Given this list of marker genes FASLG, FAS (Fas cell surface death receptor), MAP3K5, DAXX, MAPK8, MAPK9, MAPK10, here is a description of the gene set: Pathway Definition from KEGG: FASLG -> FAS -> (DAXX+ASK1) -> JNK studied in species Homo sapiens Human Gene Set: KEGG_MEDICUS_REFERENCE_FAS_JNK_SIGNALING_PATHWAY FAS-JNK signaling pathway. Pathway ID: N01056. Pathway type: Reference. Pathway class: nt06524 Apoptosis.